Given this list of marker genes GYPC, EPB41L1 (NCBI Gene Id 23260), CCDC22, MSX2, SATB2, JAG1, MOCS1, LARS1 (NCBI Gene Id 56885), NCAPG2, LRP5, DEAF1, MOCS2, ATP6V1B2, ANKRD11, MEGF8, MED13L, FLII, D2HGDH, SLX4, CLCN3 (NCBI Gene Id 133073), EDAR, DDX6, TBCE, SMC5, SEC24D, DENND5A, GLB1, IFT43, KIF7, CBL, BAP1, IQSEC2, PIK3R1, MAP2K1, DHCR24, IFT140, MAP2K2, TBCD, GNB2, CTBP1, PPP2R5D, GLI3, PALB2, COL2A1, NRAS, B3GALT6, POLR1C, ITPR1, SOX2, SLC26A2, CTNS, PTEN, ZFX, PYCR1, DSE, AXIN1, SMG8, RPS6KA3, HDAC4, COL11A2, INTU, EFNB1, IL11RA, POLR1D, FMR1, C12orf57, TBX4, MID1, MAD2L2, PPP2CA, SCN4A, USB1, SMARCD1, IDUA, CREBBP (NCBI Gene Id 1387), TRPS1 (transcriptional repressor GATA binding 1), CDC42BPB, GABRD, BICRA, COL11A1, CPLX1, FBXO11, KNSTRN, NSD1, EPB41, ITCH, IPO8 (NCBI Gene Id 10526), EP300, FZD2, SUFU, SOX5, SP7, B3GAT3, DPYSL5, BRIP1, KCNJ1, EIF5A, EDA, NONO, COL1A2, CRIPT, FANCE, HBA2, RSPRY1, SCNM1, HRAS, POLR3A, HBB, FBN2, HMGA2, SOST, AHDC1, SKIC3, KATNIP, PDPN, DLX3, HERC1, LRP4, PEX7, MTHFR, ACOX1 (acyl-CoA oxidase 1), DNA2, PRKD1, CHD1, INTS1, BGN, CHD6, OPHN1, PHEX, PTHLH, TWIST1, NTNG2, VPS35L, PRKAR1A, DYNC2H1, CKAP2L, FUCA1 (alpha-L-fucosidase 1), AGO2, CYP27B1, OSGEP, MED12, MEG3, SLC39A13, ALDH6A1, LIFR, H3-3A, GRB10, ZEB2, MPDZ, SPRTN, BRWD3, HECTD4, H3-3B, UBE2T, KYNU, EDARADD, KIAA0586, HSPG2, HSD17B4, TCIRG1, CTSK, SOX9, BRAF, UBE4B, TBX15, POLE, CYP2R1, LEMD3, GJA8, PRMT7, KLF1, ZNF148, FH, TOGARAM1, SMARCA2, EBF3, FGFR3, TRIP13, PDE6D, DVL1, CEP57, ANTXR1, LYN (NCBI Gene Id 4067), SIN3A, DDX59, GATAD2B, FLNA, ATAD3A, TRIP11, DEPDC5, SALL4, SNX14, FANCB, GRIN1, MAGEL2, CRPPA, SLC34A3, IFT56, CASZ1, ALDH18A1, AMER1 (APC membrane recruitment protein 1), DDR2, PRDM16, WDR26, ARID1B, PEX5, RNPC3, RERE, COG4, TCF20, NPR2, DICER1, TRIO, TOPORS, MTX2, ALX1, BUB3, PLCH1, PTCH1, PTDSS1, PREPL, GK, YWHAE, PAK1, CHD3, RAB39B, SLC3A1, RUNX2, PAM16, MADD, FANCF, LBR, CAMKMT, GNPNAT1, FANCI (FA complementation group I), CDH2, BMPR1A, B9D1, RFX7, PAFAH1B1, DYNC2I2, RECQL4, TRPV6, FANCA, SKI, MAN1B1, SUPT16H, MMP23B, BUB1B, CACNA1C, SIK3, SEC23A, STAG2, GPC6, DVL3, ORC1, TBC1D24 (TBC1 domain family member 24), NAA10, KIAA0753, PCGF2, SPTA1, P4HB, NFKBIA, CCDC8, NALCN, PIK3CA, WNT5A, ALG9 (ALG9 alpha-1,2-mannosyltransferase), RAD51C, PTCH2, TCOF1, SMC3, OCRL, RAI1, COX4I1 (NCBI Gene Id 1327), PRKCZ, ERI1 (NCBI Gene Id 90459), KMT2B, NFIX, NXN, B9D2, HNRNPU, KDM5A, SIX6, ATIC, TCTN3, PIGL, TMEM216 (transmembrane protein 216), MBTPS2 (membrane bound transcription factor peptidase, site 2), POU1F1 (POU class 1 homeobox 1), KDM1A, HDAC6, CHRNA7, TIMM50, INPPL1, PDGFRB, CDKN1C, PDE4D, UGP2, FGFR2, GJA5, PPP1CB, SPOP, ABL1, TMEM231, SMOC1, VANGL2, DLK1, KCNAB2, PIGN, OFD1, ARID2, FANCL, CHD5, POLD3, BUB1, ADK, FANCC, FBN1, IKBKG, FANCG, HOXD13, XRCC2, PPM1B, KIDINS220, IFT52, CRTAP, COL1A1, CTNNB1, CSGALNACT1, ACP5, B3GLCT, SNX10, TRIM37, HBA1, PDHA1, RFWD3, EMC10, EBP, BRCA1 (BRCA1 DNA repair associated), ACAN, SPECC1L, GJA1, FANCD2, CPLANE1, TONSL, WDR19, PIK3R2 (NCBI Gene Id 5296), OBSL1, ANKH, MED27, NSD2, MBD5, RTL1, CUX1, FLNB, MITF (NCBI Gene Id 7487), FBXL4, GNS, ERCC4, APC, ALX4, SPEN (NCBI Gene Id 348488), CHST3, KCTD1, SON, FAM149B1, STAT3, ERF, CLCN7 (NCBI Gene Id 7814), IGF2, PIK3CD, JARID2, RNU12, NKX6-2, PLA2G6, NEU1, THUMPD1, AP1G1, FGD1, EXTL3, WWOX, GMNN, NELFA, PNPLA6, UNC80, BRCA2, ROR2, AIP, KAT6A, LETM1, CNTNAP2, SIX2, KRAS, PURA, MMP2, POR, COL9A2, LUZP1, EDA2R, IFT122, DLX5, ALPL, FLI1, NLRP3, HEPACAM, VDR, WASHC5, SETBP1, RAD51, TGFB1, ATP6V0A2, PRIM1, SPTB, GNE, MAN2B1, FGFR1, NFIA, WDR35, CWC27, DYNC2I1, MTOR, KPTN, CUL7 (cullin 7), PIGG, GPR101, CSPP1, POLR1B, MEN1, FANCM, IFT80, HK1, COX5A, PLAG1, here is a description of the gene set: Human Gene Set: HP_ABNORMAL_FRONTAL_BONE_MORPHOLOGY Abnormal frontal bone morphology An abnormality of the frontal bone. species: Homo sapiens